Given this list of marker genes ZNF608, HOXA3, TBC1D10B, NRXN1 (NCBI Gene Id 9378), NFE2L1, TFE3, SCRT2, NSG2, TSN, MCF2L, HOXC8, SOX11, NEXMIF, OTP, RAP1B, KCNK12, CELF4, TEAD3, AP1G1, PTPRU, here is a description of the gene set: Genes having at least one occurence of the motif GCGCTTT in their 3' untranslated region. The motif represents putative target (that is, seed match) of human mature miRNAs hsa-miR-518b, hsa-miR-518c and hsa-miR-518d (v7.1 miRBase). Human Gene Set: GCGCTTT_MIR518B_MIR518C_MIR518D studied in species Homo sapiens